Given this list of marker genes Rbm10, Ran, Xpo1, Sdad1, Nup88, Nmd3, Npm1, Mdn1, here is a description of the gene set: Mouse Gene Set: GOBP_RIBOSOMAL_LARGE_SUBUNIT_EXPORT_FROM_NUCLEUS The directed movement of a ribosomal large subunit from the nucleus into the cytoplasm. studied in species Mus musculus